The following is a description of a gene set: The chemical reactions and pathways resulting in the breakdown of a nucleobase-containing small molecule: a nucleobase, a nucleoside, or a nucleotide. Human Gene Set: GOBP_NUCLEOBASE_CONTAINING_SMALL_MOLECULE_CATABOLIC_PROCESS species: Homo sapiens, and this is the list of marker genes: CDA, ADA, MAPDA, ENTPD4, MGAT1, GSK3A, DERA, DCTD, CDADC1, APOBEC3G, ENPP4, UPB1, PNP, ADA2, ENTPD7, AICDA, APOBEC3C, XDH, GDA, UPP1, NUDT1, MTAP, DPYD, UPP2